The following is a description of a gene set: studied in species Mus musculus Mouse Gene Set: GOBP_DENDRITIC_TRANSPORT The directed movement of organelles or molecules along microtubules in dendrites., and this is the list of marker genes: Kif5c, Kif2a, Kif5b, Kif3b, Rabgef1, Kif17, Wasf1 (NCBI Gene Id 83767), Pura, Stau2, Sfpq, Flot2, Rab17 (RAB17, member RAS oncogene family), Kif21b, Kif5a, Kifap3, Stau1, Hnrnpu, Trak2, Kifc2, Kif3a